Given this list of marker genes LASP1, BICDL2, ARHGAP5, SLC29A3 (NCBI Gene Id 8072), SPNS2, IL2, CASTOR2, ARRB1, ERCC8, ACSS1, GSG1L, PTPN14, MAP3K1, SEC24C, KCNH7, MTMR11, COL6A1, TMED1, GFER, EPN3, ALDH16A1, PRX, ARMC3, CNTN2, OAZ2, MTCL2, WTAP, FMNL2, THBD, SCN4B, GPRC5B, MCHR1, NT5M, KRT4 (keratin 4), PAK6-AS1, RAP1GAP2, GALNT14, AFF4, HTT, SEPTIN8, CDT1, SNX12, P2RY2, CACNB1, TRIM66, ZNF396 (NCBI Gene Id 252884), IRX2-DT, RORB, NPTX1, RAD23B, C11orf87, ADAMTS19 (ADAM metallopeptidase with thrombospondin type 1 motif 19), DEPTOR, PCDH9 (protocadherin 9), KIF3B, TMEM221, PLIN3, TRAM1, KLK8, NDUFB11, ZNFX1, GLDN, SLC7A6, SERF2 (small EDRK-rich factor 2), here is a description of the gene set: Genes predicted to be targets of miRBase v22 microRNA hsa-miR-1225-3p in miRDB v6.0 with MirTarget v4 prediction scores > 80 (high confidence targets). Human Gene Set: MIR1225_3P studied in species Homo sapiens from publication Chen Y, Wang X (PMID 31504780)